Given this list of marker genes MYOZ2, AKAP5, SOD1, ATP2B4, SLC9A1, CACNG8, PPP3CB, NFATC1, here is a description of the gene set: species: Homo sapiens Binding to a protein phosphatase 2B. Human Gene Set: GOMF_PROTEIN_PHOSPHATASE_2B_BINDING